The following is a description of a gene set: CD4 T follicular helper (Tfh) cells provide the required signals to B cells for germinal center reactions that are necessary for longlived antibody responses. However, it remains unclear whether there are CD4+ memory T cells committed to the Tfh lineage after antigen clearance. Using adoptive transfer of antigen-specific memory CD4+ subpopulations (based on CXCR5 and Ly6c expression)in the LCMV infection model, we found that there are distinct memory CD4+ T cell populations with commitment to the Tfh and Th1 lineages. Our conclusions are based on gene expression profiles, epigenetic studies and phenotypic and functional analysis. The gene expression profiles of virus-specific CD4 T cell subets at effector and memory stages is presented here. from publication Hale JS, Youngblood B, Latner DR, Mohammed AU, Ye L, Akondy RS, Wu T, Iyer SS, Ahmed R (PMID 23583644) species: Homo sapiens Genes up-regulated in follicular helper CD4 SMARTA T cells (Tfh): effector during acute infection of LCMV versus memory. Human Gene Set: GSE43863_DAY6_EFF_VS_DAY150_MEM_TFH_CD4_TCELL_UP, and this is the list of marker genes: ATP6V0D1, MARCKSL1, ZNF687, XBP1, MAP2K3, PHLPP1, SDC3, MYO1E, IRAK2, SLC25A34, SRPK2, NAB1, PCYT1A, CD86, STAT1, LGALS3BP, RNF14, STARD4, PRXL2A, SAA1, ILF3, GDI1, VPS37B, RAD21, RMND5B, MFAP1, BEX3, MX2, MARCKS, VAMP2, PEA15 (NCBI Gene Id 8682), IRF7, TSC22D2, POU6F1, LITAF, TCEAL9, ZNFX1, UBP1, IFIT1B (interferon induced protein with tetratricopeptide repeats 1B), TXNDC16, TECPR1, TSPYL1, ALDH1A1, SLFN12, ADAR, MYO1B (NCBI Gene Id 92451), CCRL2, ST3GAL5, TCF12, PHYHD1, TP53INP2, EMILIN2, PPP1CB, RBM39, LAPTM5, SNAP29, EGFL6, PAPOLG (NCBI Gene Id 64895), PMEPA1, CACNA1F (NCBI Gene Id 778), COQ8A, ISG20, EEF2, NR4A2, MAS1, FIBCD1, MED14, PARP12, BACH1, USP18, FTL, AHR, FAM43A, RIGI, PMP22, NDEL1, CBX4, RHOQ, RTP4, CMPK2, CRIP3, CA13, GPSM2, CABLES1, SIRT2, FABP5, FRMD4A, LYSMD3, TBC1D15, DCK, HLA-DQA1, IFIT3, MAFK, THRAP3, NAMPT, PDCD10, RAMP2, SEC24A, DSCC1, FAM170A, ZNF367, LEMD3, CD84, GTPBP2, ACAP1, KRAS, LAT2, CYFIP2, RGS2, DMXL1, PLK2, HSP90B1, RBPJ, INO80, KMT2E, PRPF38B, IFI44, CLINT1, IL33, PIK3AP1, OPLAH (5-oxoprolinase, ATP-hydrolysing), ATP2B1 (NCBI Gene Id 490), TGFB1, IVNS1ABP, ICAM5, RGS1, MAPK1IP1L, TPST2, OSBPL3, ATP6V0A1, TMEM40, SNAI3, SMAD3, WDR1, GOLGA4, HSPA5, PTGER4, LRRC8D, CD28, SPAG9, XAF1, RNF114, CHGA, C9orf50, OAS1, UBE2D1, IFIT2, HIF1A (hypoxia inducible factor 1 subunit alpha), SP110, HECA, H3-5, PDE1B, HELZ2, LAT, ZNF800, GALR2, DHX58, IFI35, KTN1, LZTFL1 (leucine zipper transcription factor like 1), RSAD2, SSBP4, RGS13, ABAT, EGR3, S1PR3 (sphingosine-1-phosphate receptor 3), NEAT1, CD300LF, ZFAND5, ITGB4, GUCD1, IL6R, TUBB2B, REL, SPP1, HNRNPR (NCBI Gene Id 10236), ZFP36L1, NFATC1, SAMSN1, TLR7, RETREG1, CBX7, ATP6V1D, TMEM184B, CDK2 (cyclin dependent kinase 2), GRAMD4, PLAC8L1, MIDEAS, GPR183, LGALS9B, FOXN2, NKAIN4 (NCBI Gene Id 128414), WDR26, IRS2, RASD1, UBE2L6, VARS2, STAP1, HNRNPF